The following is a description of a gene set: Human Gene Set: GSE41867_DAY8_VS_DAY15_LCMV_CLONE13_EFFECTOR_CD8_TCELL_UP species: Homo sapiens from publication Doering TA, Crawford A, Angelosanto JM, Paley MA, Ziegler CG, Wherry EJ (PMID 23159438) During acute viral infections, naïve CD8+ T cells differentiate into effector CD8+ T cells and, after viral control, into memory CD8+ T cells. Memory CD8+ T cells are highly functional, proliferate rapidly upon reinfection and persist long-term without antigen. In contrast, during chronic infections, CD8+ T cells become “exhausted” and have poor effector function, express multiple inhibitory receptors, possess low proliferative capacity, and cannot persist without antigen. To compare the development of functional memory T cells with poorly functional exhausted T cells, we generated longitudinal transcriptional profiles for each. Genes up-regulated in CD8 T effector cells during chronic infection with LCMV-Clone 13: day 8 versus day 15., and this is the list of marker genes: KALRN, MOB4, CEP57, CDK10, SGMS1, KLHL15, ZNF692, HMCES, ACOT2, ANKRD44, CPM, BSDC1, XPO4, BLOC1S4, MYO7B, MAPK7, CXXC5, TMEM163, C15orf39, CRIP1, TUT7, LY6D (NCBI Gene Id 8581), MAP1LC3A, SIPA1L3, SERINC3, FLT3, PHF21A, ZDHHC17, MAFG, FKBP7, ULK2, CDC37L1, TNKS, RAD18, CLK4, NSF, CDKN1B, EPC1, CUX1, GPBP1, BCL10, MDN1 (NCBI Gene Id 23195), STEAP3, DPH5, SARAF, RIN3, IL23A, EIF1, SIAH2, ABT1, SMPDL3A, APOLD1, NRROS, ING3, RELCH, USP22, CEP120, PCNX1, DFFA, USP16, CDKN2AIP, AZI2, VAMP2, CEPT1, TRAF4, CYP4F3, RASGRP1, ILDR1, HSD17B8, CDK11B, RGS3, PHLDA1, EARS2, CHSY1, KDM7A, GRAP2, FYN, MTMR3, NKTR, SH3PXD2A, DVL1, BAZ2B, SLC26A11, PPP2R1A, NFAT5, CLINT1, ATP2B1, CEP70, SAFB2, DAZAP2 (NCBI Gene Id 9802), TAGLN, CRAMP1, GINM1, TACC1, KLHL17, CELF2, UBAC2, GLA, RDH10, HERPUD2, TRA2A, CDT1, RGL2, KLF7, RPL22L1, PCM1, AFF4, KDM4C (lysine demethylase 4C), MKNK1, DUSP5, ABCA1, RNF125, FGD6, NXF1, SLC20A2, IL10, NECAP1, PRKCZ, LEMD2, HNRNPDL, PIGS, CTLA4, WASL, ADRB2, CD93, SYF2, ARMCX5, ZNF326, ITPRIP, TSR2, LRIG2, SMG1, ETS1, SKI, SKIL, SPECC1L, SDHAF1, ITPKC, PRAMEF8, PECAM1, COQ10A, RC3H1, IL7R, GEM, ZNF148, WSB1, ART3, ACTRT3, SNRK, MIDEAS, MBTD1, SIDT2, SGK3, USP6NL, ADCY7, ATG101, SF1, SLC25A36, C15orf61, SMG6, PTPRJ, CREBBP, TRIM11, ATG16L1, SRSF6, PUM1, ZBTB2, IL6R, SLC9A8, IL6ST, FOXP1, ZNF653, EEIG2, BCL7B, THBS3, KRIT1, LEMD3 (LEM domain containing 3), PNISR, PRDM2, KCTD3, CSGALNACT2, TMEM167B, GNL3L, PHC1, ADPGK, MED15, TOB2, IKZF5, SNX33, GALNT11, PTP4A2, FAM168B, SP1, MYSM1, NIBAN3, REL, MOSPD3, KLHL24, MTMR12, CERT1